Given this list of marker genes ABHD6, GK5, GPAT2, GK, GPD1L, GK2, ACP6, GPD2, GPAT3, GPD1, here is a description of the gene set: studied in species Homo sapiens Human Gene Set: GOBP_ALDITOL_PHOSPHATE_METABOLIC_PROCESS The chemical reactions and pathways involving alditol phosphates, any phosphorylated polyhydric alcohol derived from the acyclic form of a monosaccharide by reduction of its aldehyde or keto group to an alcoholic group.